The following is a description of a gene set: Mouse Gene Set: GOBP_MALE_GAMETE_GENERATION studied in species Mus musculus Generation of the male gamete; specialised haploid cells produced by meiosis and along with a female gamete takes part in sexual reproduction., and this is the list of marker genes: H2ax, Spag6l, C2cd6, Sstr1, Fsip1, Septin7, Clgn, Ift81, Ctsl (NCBI Gene Id 320361), Ndc1, Sfmbt1, Xlr4a, Pdcl2, Nsun2, Ccdc159, Slc26a6, Cdyl, Vipas39, Fndc3a, Gmnc, Zpbp, Agfg2, Ccdc42, Jam3, Adad1, Mir449c, Galnt3, Dnhd1, Ddias, Hsf2bp, Stk11, Gm20736, H2bc1, Adam7, Bbs2, Oca2, Nek1, Golga3, Cfap206, Syne1, Immp2l, Tesk1, Ubb, Gpx4, Afg2a, Adig, Ica1l, Semg1, Neurl4, Ptch1, Eif4g3, Ift88, Gm14525, Cetn2, Txndc8, Pax5, Ercc1, Sox17, Dpy19l2, Dmc1, Gm10488, Tex14, Npr2, Piwil4, Rad51c, Cabcoco1, Pxt1, Prdm9, Axl, Gm21627, Atn1, Cdc25c, Tesk2, Crkl, Septin4 (septin 4), Catspere2, Six5, Meiosin, Trp53, Alms1, Cabs1, Pgam2, Mei1, Gjb3, Adad2, Zfp39, Cntln, Dcaf17, Spata31, Foxa3, Sppl2c, Ccnyl1, Nup210l, Gm28510, Ift27, Tmem119, Sox3, Mycbpap, Dzip1, Calr3, Msh4, Ovol1, Cabyr, Map7, Sirt1, Hormad1, Katnal1, Mlh3, Adcyap1r1, Slc19a2, Sycp1, Piwil1, Hsf1, Ggt1, Dmrt1, Tex15, Armc3, Prok2, Meikin, Tmprss12, Spata20, Dnah1, Atrx (NCBI Gene Id 67403), Septin14, Catsper4, Rai14, Dhh, Pafah1b3, Dmxl2, Pank2, Cnbd2, Sun5, Frey1 (Frey regulator of sperm-oocyte fusion 1), Armc2, Cfap53, Zfy2, Pdilt, Xrn2, H3f3b, Rhbdd1, Ttll8, Adam24, Ccnb1ip1, Mst1, Svs3a, Xlr5b, Slc22a14, Fhad1, H2aj, Tpgs1, Poc1b, Upf3a, Trp63 (transformation related protein 63), Tssk2, Gm5168, Dnali1, Ddx4, Mamld1, Tnk2, Gm38999, Ift56, Rimbp3, Pln, Jam2, Nlrp14, Zfp35, Yy1, Usp42, Tssk6, Rad21l, Rnf8, Vps54, Larp7, Ppp1cc, Mfsd14a, Defb1, Lgr4, Boll, Catsperz (NCBI Gene Id 77926), Gopc (NCBI Gene Id 94221), Spata25, Kdm3a, Neurl1a, D1Pas1, Patz1, Smad4, Prss42, Spdya, Catspere1, Ddx25, Mcmdc2, Spem3, Gm2012, Cnot7, Ccdc38, Cadm1, Ct55 (cancer/testis antigen 55), Tex19.1, Psma8, Pygo2, Spata6l, Sbf1 (SET binding factor 1), Atat1 (NCBI Gene Id 73242), Cfap52, Dlec1, Spocd1, 1700102P08Rik (NCBI Gene Id 112418), Hadh, Bax, Ccna1, Dhx36, Ift20, Pnldc1, Tssk4, Gm6121, Slc4a2, Gm28102, Fbxo24, Gamt, Ap3b1, Izumo3, Gal3st1, Rec8, Tex11, Tdrd7, Sufu (NCBI Gene Id 72652), Nanos3, H1f1, Ing2, Wipf3, Prdx4, Tex19.2, Zfp449, Armc12, Shisa6, Zglp1, Gm21865, Rhox8, Fscn3, Zscan2, Xlr, Mns1, Igf2r, Zfp296, Mlh1, Adam18, Bmp8b, Svs3b, Ttc21a, Acox1, Cip2a, Ift25, Lztfl1, Scmh1, Zmynd15, Efcab9, Tsnaxip1, Ubr2, Nme8, Crem, Odf2, Vps13b, Mybl1, Bsg, Lrrk2, Kash5, Crtap, Gm5934, Tbata, Fam209, Tnp2, Bsph1, Hmga1, Gm4297, Celf3 (NCBI Gene Id 78784), Ythdc1, Catsper3, Gm29554, Zfp628, Prss21, Calr, Psme4, Tdrd12 (NCBI Gene Id 73691), Gm1140, Cul4a, Pafah1b2, Dld, Dazap1 (DAZ associated protein 1), Bscl2, Fshb, Drc1, Gm2030, Ago4, Ccr6, Hoxa11, Cfap91, Msh6, Stk33, Mir34b, Acsbg2, Pcyt1b, Misfa (NCBI Gene Id 629141), Mir34c, Iqcf1, Mcidas, Gja1, Brme1, Tppp2, Ccin, Morn2, Catsperd, Hoxa10, Wdr48, Mir449b, Ros1, Cfap221, Spinkl, Topaz1, Dedd, Mov10l1, Gm7958, Serpina5, Hspa2, Prm2, Gm21858, Rnf151, Pithd1, Ssh2, Snrpa1, Ccdc146, Gm28919, Eif2s3y, Axdnd1, Gli1, H3f4, Prm1, Sass6, Spmap2, Nme5, Catsper1, Lrrc8a, Bckdk, Zfp41, Abhd2, Cfap97d1, Actl9 (NCBI Gene Id 69481), Cdk16, Gm5169, Cfap47, Meig1, Mea1, Herc2, Tdrd6, Odad3, Lrrc46, Slc9c1, Adcy10, Terb2, Pla2g3, Cimap1a, Catsperg2, Stra8, Ntrk1, Lhcgr, Ggn, Hook1, Racgap1, Tbc1d21, Dnmt3a, Epc1, Fanca, Zcwpw1, Cfap61, Cftr, Bcl2l11, Mroh2b, Brdt, Poc1a, Zfp541, Ythdf2, Txnrd3, H1f9, Prss44, Btbd35f1, Gsr, Meiob, Styx (NCBI Gene Id 80592), Spag8, Xlr3c, Gtsf1, Ccdc33, Slco4c1, Tlk2, Tspan8, Hps1, Ankrd49, Nr0b1, Tdrp, Spata6, Nanos2, Garin3, Prkaca, Btbd18, Tmem232, Gorasp2, Rnase9, Rab1a, 3830403N18Rik, Lrguk, Fkbp6, Actl7a, Gm20890, Cfap70, Nr5a2, Zbtb16, Siah1a, Fancg, Catsperb, Bcl2l1, Chd5, Rbp4, Tsnax, Tdrd9, Tuba8, Arrdc5, Suv39h2, Bmal1, Ttll1, Garin5b, H3f3a, Mael, Pebp1, Asb17, Agfg1, Nr2c2, Kdm5a, Ak7, Gm29866, Ttc12, Spata22, Spata32, Cep131, Gm20817, Nr6a1, Spink1, Tssk5, Cib1, Pmfbp1, Septin6, Arid4b, Gm20843, Slirp, Hmgb2, Mei4, Shcbp1l, Spef2, Gm29276, Phc2, Spatc1l (NCBI Gene Id 76573), Gm20824, Wt1, Pgm3, Cox7b2, 4930447C04Rik, Txndc2, Dmrtc2, Hrob, Usp26, Sec23ip, Tbpl1, Tle6, Sstr3, Adgb, Gm21760, Garin1b, Tle3, Ube2j1, Dnmt3l, Defb37, Gm21996 (predicted gene 21996), Fshr, Slc26a8, Mettl14, Drc7, Pou4f2, Ccdc63, Setx, Piwil2, Herpud2, Pfn4, Hspa1l, Creb3l4, H2al2a, Adam26a, Skil, Rgs2, Slxl1, Zfp42, Slc25a31, Pias1, Spmip6, Bnc1, Inhbb, Il1a, Slc26a3, Slx, Cep128, Bag6, Osbp2, Ttll5 (NCBI Gene Id 97844), Asz1, Morc1 (microrchidia 1), Mas1, Tnp1, Gm10230 (predicted gene 10230), Rad18, Ehmt2, Prnd, Krt9, Sun1 (NCBI Gene Id 77053), Dicer1, Spag6, Trip13, Spem1, Tdrd5, Adamts2, Adam1b, Atm, Gata4, Mir449a, Paip2, Tmf1, Ythdc2, Dnd1, Zc3h14, Spmip7, Iho1 (interactor of HORMAD1 1), Sycp3, Tcp11x2, Tmem203, Septin2, Bcap31, Gm20820, Cit, Sox9, Gm21117, Prm3, Hfm1, Xlr4b, Sgo2a, Hoatz, Klhl10, Herc4, Yif1b, Acvr2a, Btg1, Scaper, Nectin2, Galntl5, Bbs4, Fsip2 (fibrous sheath-interacting protein 2), Ybx3, Zfx, Utp14b, Ttll3, Rbx1-ps, Sly, Vdac3, Plekha1, Strbp, Spaca1, Rsph6a, Bltp1, Cyp26b1, Tslrn1, Cep57, Nphp1, Pld6, Garin1a, Dnaaf3, Kit, Meioc, Bbof1, Ybx2, Xlr3a (X-linked lymphocyte-regulated 3A), Zscan21, Pcsk4, Fancf, Tdrkh, Cnr1, Fignl1, Hsf2, Cfap44, Cfap58, Spata46, Spata9, Nkd1, Ggnbp2, Tarbp2, Kat5, Gk2, Cylc1, Sox30, Bik, Src, Sohlh1, Brca2, S100a11, Zmynd12, Nup62, Mast2, Aff4, Zfp37, Ccno, Akap4, Shbg, Cldn11, Khdrbs1, Gm773, Rfx2, Zpbp2, Clock, Dazl, Gm5935, Foxj3, Adamts16, Htt, Ropn1 (ropporin, rhophilin associated protein 1), Gm21095, Gmcl1, Atp2b4, Tsga8, Cfap65 (cilia and flagella associated protein 65), Atp1a4, Bmp8a, Nicol1, Spata16, Garin5a, Rnf17, Inpp5b, Tdrd1, Rb1, Tesmin, Adrm1, Ube2b, Qki, Rbm46, Odf4, Spag16, Mertk, Notch1, Rec114, H1f6, Rnf114, Ace (angiotensin I converting enzyme), Garin2, Sohlh2, Prkg1, Ghsr, Sycp2, Slc9a8, Dpcd, Foxj2, Ccdc34, Cntd1, Gm28870, Rpl39l, Bcl6, Odf1, Celf1, Ccdc87, Selenof, Adam25, Gm1993, Rad23b, M1ap, Spata24, Arid4a, Kctd19, Jag2, Chn2, Rspo1, Taf7l, Cfap69, AU040320, Pacrg, B4galnt1, Hoxa9, Iftap, H1f7, Cfap57, Pum1, Hsf5, Sgpl1, Ccdc62, Bsph2, Tug1, Rpl10l, Spag17, Chtf18, Calca, Nkapl, Apob, Alkbh5, Garin4, Sox8, Eqtn, Mgat4d, Tssk3, Klc3, Kif18a, Kdm2b, Tyro3, Sry, Limk2, Gm20870, Hmga2, Gm28961, Sod1, Taf4b, Spo11, Pafah1b1, Catsper2, Cfap157, Rbx1, Spag4, Csnk2a2, Rsph1, Mcm8 (NCBI Gene Id 66634), Mkrn2, Syce3, 1700013H16Rik, Etv5 (NCBI Gene Id 75752), Aspm, Cfap54, Tssk1, Acrbp, Cfap43, Rln1, Mettl3, Pygo1 (NCBI Gene Id 72135), Ggnbp1, Cylc2, Prss43, Gm28576, Xlr5a, Tbc1d20, Ccdc136, Lamp1, Insl6, Slc22a16, Fxr1, Cfap119, Brip1 (BRCA1 interacting protein C-terminal helicase 1), Sstr2, Spata19, Majin, Parp11, Xlr3b, Gm21294, Rgn, Xlr4c, Xlr5c, Tcp11, Dnaja1, Akap9, Ropn1l, Ar, Spata2, Mkks, Iqcn, Arhgap33os, Gm20911, Iqcg, Spink2